Given this list of marker genes LMNA, TRPC3, PPARG, MIR34B, MIR214, APLNR, PPP3CA, FOXO1, BMP10, MIR25, MIR208A, ATP2B4, MLIP, MIR20A, SMAD3, MIR34C, MIR17, ERRFI1, MIR199A1, ACACB, here is a description of the gene set: studied in species Homo sapiens Any process that modulates the rate, extent or frequency of the process in which cardiac muscle adapts, with consequent modifications to structural and/or functional phenotypes, in response to a stimulus. Stimuli include contractile activity, loading conditions, substrate supply, and environmental factors. Human Gene Set: GOBP_REGULATION_OF_CARDIAC_MUSCLE_ADAPTATION